The following is a description of a gene set: Human Gene Set: GOMF_HISTONE_H3K9_METHYLTRANSFERASE_ACTIVITY Catalysis of the reaction: S-adenosyl-L-methionine + histone H3 L-lysine (position 9) = S-adenosyl-L-homocysteine + histone H3 N6-methyl-L-lysine (position 9). This reaction is the addition of up to three methyl groups to the lysine residue at position 9 of the histone H3 protein. studied in species Homo sapiens, and this is the list of marker genes: PRDM8, MECOM, SETD5, ASH1L, PRDM2, EHMT1, PRDM9, PRDM16, EHMT2, SETDB1 (NCBI Gene Id 9869), SUV39H2 (SUV39H2 histone lysine methyltransferase), SUV39H1, SETDB2